The following is a description of a gene set: The chemical reactions and pathways resulting in the formation of a pigment, any general or particular coloring matter in living organisms, e.g. melanin. species: Mus musculus Mouse Gene Set: GOBP_PIGMENT_BIOSYNTHETIC_PROCESS, and this is the list of marker genes: Iba57, Myo5a, Snx3, Cox10 (NCBI Gene Id 70383), Hnf1a, Ctns, Appl1, Fech, Pgrmc1, Tmem14a, Oca2, Rab38, Rpe65, Atp5if1, Mc1r, Atp7a (NCBI Gene Id 51824), Wnt5a, Ppox, Mfsd12, Rapgef2, Hmbs (hydroxymethylbilane synthase), Cox15, Urod, a, Slc45a2, Cdh3, Zeb2, Alas2, Opn3, Srrd, Slc7a11, Slc24a5, Abcb7, Uros, Ddt, Trpc1, Cpox, Tyr, Sox2, Fxn, Slc11a2, Ireb2, Cited1, Tyrp1, Alas1, Tmem14c, Slc6a9, Alad, Abcb10 (ATP-binding cassette, sub-family B member 10), Slc25a39 (solute carrier family 25, member 39), Gipc1, Pmel, Dct